Given this list of marker genes BAAT, VDR, CYP3A4, ABCB11 (ATP binding cassette subfamily B member 11), NR1H4, SULT2A1, ABCB1, ABCC3, CYP7A1, SLC51B, ABCC2, ABCC4, NR1I3, SLCO1B1, NR1I2, SLC10A1, SLC51A, here is a description of the gene set: Drug induction of bile acid pathway Human Gene Set: WP_DRUG_INDUCTION_OF_BILE_ACID_PATHWAY species: Homo sapiens